Given this list of marker genes Chuk, Hjv (hemojuvelin BMP co-receptor), Trf, Cd81, Ikbkg, Hfe, Snx1, Nicol1, Ikbkb, Snx2, Snx4, Rgma, here is a description of the gene set: species: Mus musculus Mouse Gene Set: GOMF_TRANSFERRIN_RECEPTOR_BINDING Binding to a transferrin receptor.